Given this list of marker genes AGO2, SP1 (NCBI Gene Id 6667), JUP, CDH9, CDH2, ACTG1, CDH10, CLDN12, NECTIN4, CDH11, ADAM33, CLDN7, CLDN2, SDK2, CADM3, PARD6B, BHLHE22, CLDN23, CTNNA1, CADM2, CDH7, TNRC6A, CDH1, CLDN17, MIR200C, PARD6A, PATJ, PVR, CLDN3, CDH6, PARD3, CLDN22, CDH24, CTNNB1, ANG, CLDN5, CDH4, ZEB2, CLDN1, SOX10, NECTIN1, CDH8, MOV10, CLDN4, NECTIN3, CDH18, CLDN8, PARD6G, CDH3, CDH5, AGO1, CDH12, CLDN16, HOXC8, CDH19 (NCBI Gene Id 28513), TNRC6C, SDK1, CLDN9, CLDN19, ANGPTL4, NECTIN2, SNAI1, AMOT, ADAM19, CRB3, FOXF1, TNRC6B, CLDN6, CLDN14, CLDN18, CADM1, PRDM8, CLDN11, AGO3, ZC3H12A, F11R, HEYL, CLDN15, PRKCI, AGO4, CLDN20, AFDN, PALS1, CDH13, CDH17, ACTB, CTNND1, CLDN10, ILF3, CDH15, here is a description of the gene set: Human Gene Set: REACTOME_CELL_CELL_JUNCTION_ORGANIZATION species: Homo sapiens Cell-cell junction organization